Given this list of marker genes Macroh2a2, Macroh2a1, Nol11, Ddx11, Dedd (death effector domain-containing), Nop53, Mtor, Pih1d1, Pwp1, Ncl, Smarcb1, Mars1, Sirt7, Ippk, Smarca4, here is a description of the gene set: Any process that modulates the frequency, rate or extent of transcription of nuclear large rRNA mediated by RNA polymerase I. species: Mus musculus Mouse Gene Set: GOBP_REGULATION_OF_TRANSCRIPTION_OF_NUCLEOLAR_LARGE_RRNA_BY_RNA_POLYMERASE_I